Given this list of marker genes Sirt1, Fbxo5, Actl6b, Pbrm1, Dpf1, Mad1l1, Bcl7c, Dpf3 (NCBI Gene Id 97800), Chfr, Cdca8, Rmi2, Mad2l1, Smarce1, Zfp207, Nek6 (NIMA (never in mitosis gene a)-related expressed kinase 6, NCBI Gene Id 80473), Smarcd3, Ccnb1-ps, Pcid2, Smarcc2, Knl1, Psmg2, Hecw2, Phf10, Dync1li1, Rad21 (RAD21 cohesin complex component), Ndc80, Smarcc1, Actl6a, Tacc3, Apc, Anapc2, Bub1 (BUB1, mitotic checkpoint serine/threonine kinase), Prap1, Ska1, Anapc15-ps, Cep192, Cdc27, Mos, Anapc1, Plk1, Cdc16 (NCBI Gene Id 72610), Trip13, Tpr, Smarcd1, Cit, Zwint, Smarcb1, Klhl22, Anapc15, Usp44, Cul3, Atm, Cdc23, Dpf2, Smarcd2, Actb, Bub1b, Arhgap33os, Anapc4, Smarca4, Tex14, Kntc1, Nsmce2, Nuf2, Rb1, Ube2u, Xrcc3, Brd7, Numa1, Incenp, Bcl7a, Spdl1, Zwilch, Hnrnpu, Riok2, Prpf4b (pre-mRNA processing factor 4B), Aurkb, Cenpe, Arid2, Arid1a, Anapc7, Ube2c, Spc25, Khdc3, Birc5, Cdk5rap2, Becn1, Mad2l1bp (MAD2L1 binding protein), Zw10, Cdk1, Ccnb1, Mapk15, Ttk, Kat5, Anapc11, Gen1, Bcl7b, Lcmt1, Smarca2, Cdc6, Kat2b, Dusp1, Cdc20, Bub3, Ik, Ska3, Spc24, Anapc5, Haspin, here is a description of the gene set: Any process that modulates the frequency, rate or extent of sister chromatid segregation. Mouse Gene Set: GOBP_REGULATION_OF_SISTER_CHROMATID_SEGREGATION species: Mus musculus